Given this list of marker genes TCOF1, GJA5, TWIST2 (twist family bHLH transcription factor 2), GJA8, SF3B4, here is a description of the gene set: Abnormality of lower eyelashes studied in species Homo sapiens Human Gene Set: HP_ABNORMALITY_OF_LOWER_EYELASHES